The following is a description of a gene set: Human Gene Set: ACTGAAA_MIR30A3P_MIR30E3P Genes having at least one occurence of the motif ACTGAAA in their 3' untranslated region. The motif represents putative target (that is, seed match) of human mature miRNAs hsa-miR-30a-3p and hsa-miR-30e-3p (v7.1 miRBase). studied in species Homo sapiens, and this is the list of marker genes: SP3, QKI, NRARP, GALNT1, YOD1, TNPO3, DBF4, ERMP1, POLR2M, MAPK6, PAIP2, DUSP8, MACIR, AHCYL2, MARK1, KRAS, TCEANC2, FOXJ3, ACACA, ERBB4, FRAT1, HNRNPH2, CANX, TOP1, NR3C1, MEF2C, HERC4, CCDC74A, C5orf24, ZBTB21, RICTOR, UBE2J1, EPAS1, TMEM45B, CREBBP, ARID4A (AT-rich interaction domain 4A), CLCN5, VCF1, SIAH1, RYR3, TOMM70, SEMA3C, OSBPL11, DDX3X, NR2C2, LRRTM2, IPCEF1, ARPP19, NRCAM, PAPOLG, FAM13B, BCCIP, OTX2, FGF7, TNRC6B, GDF6, PRRX1, RBMX, MNT, LRRTM1, RBM45, RUNX1T1, PURA, PRKAA1, MYT1L, UBE2G1, CSNK1G3, BIRC6, LCP2, VAMP2, CELF2, NHS, ZBTB18, DSCAM, SAP130, LMNB1, USP1, EGR1, SRSF10, MED12L, ZFYVE9 (NCBI Gene Id 9372), TBL1XR1, SRSF4 (serine and arginine rich splicing factor 4), ZEB2 (NCBI Gene Id 9839), RAD51D, TSC22D2, ZIC4, STX3, RARB, CCKBR, TOB1, FOCAD, MLLT10, MACROD2, PBRM1, ISCU, ELAPOR2, CDC40, TWF1, MECP2, DBX2, RBMXL1, SH3GLB1, ABRAXAS2, COL12A1, MEOX2, PSIP1, FBXW7, SCAMP1, USP6, POU4F1, NUFIP2, PTEN, ZNF22, TMEM47, KCNA3, NAA25 (N-alpha-acetyltransferase 25, NatB auxiliary subunit), CBL, ADCY1, ADAMTS5, APC, VGLL3, YWHAE, DLST (NCBI Gene Id 1743), HNF1B, AKAP9, EYA3, AP2B1, FNDC5, HMGA2 (high mobility group AT-hook 2), FCHO2, SLC25A33, SFRP1, ANTXR2, EIF1, CDC37L1, ZNF280B, PPP2R5E, AP4E1, SAMTOR, SIX4, CAPRIN1, IFT20, CCDC74B, PITX2, FXR1, HEXIM1, RALA, GALNT7, KIAA0232, ACYP2, INTS8, ROBO1, EP300, ARF6, FGF7P6, ATXN1, ELK3, RAB10, RNF141, FOXK2, OSBPL6, SLITRK3, DHDDS, MEF2D, SH3GL3, TSPAN14, HIRA, ATP1A1, LIN7A, DNAJC27, BRCA1, LHX8, TFDP1, BAAT, ORC5, DLG2, CAV1, DNAJB14, CYTH1, NEGR1, CNPY2, RGS7, YPEL5, AP1G1, CCDC6, PIGA, TCF7L1, SELENOW (selenoprotein W), ZFAND5, NPY2R, SUN2, NKAIN2, ZFX, FOXP1, FGF7P3, VCPIP1, PATZ1, CYRIA, DNAJB4, USP32P2, CSNK1E